Given this list of marker genes AMOT (angiomotin), KANK4, KEL, HDAC6, SEMA5A, BORCS8, MKKS, ESAM, ACTN2, ADD3, SLC12A9, SSH3, CRABP2, SEMA3G, RASA1, WNT3, TMOD2, CCL24, SNAPIN, RB1CC1, SLC12A4, DEPTOR, RAB3B, NAA80, SPTA1, DMTN, C15orf62, MIR214, ADNP, RND2, SPTBN1, ISLR2, CFL2, FCHSD1, HP1BP3, HCK, VIL1, DAAM2, ANO6, NCKAP1L, CORO1A, MEGF8, TMSB4X, WDTC1, STK39 (NCBI Gene Id 27347), CLCN6, NRP1 (NCBI Gene Id 8829), FCHSD2, ABITRAM (actin binding transcription modulator), ARHGAP40, LMOD3, SRF, CLNS1A, SPTBN2, COTL1, BORCS5, USH1C, DISC1, CXCL12, EDN1, CDKL3, CAPZB, ATP13A2, SWAP70 (NCBI Gene Id 23075), NPHS1 (NCBI Gene Id 8183), CHMP3, ZFYVE27, VAV2, SHTN1, PAK3, PYCARD, GSK3B, ALOX15, UCN, NKX6-1 (NCBI Gene Id 4825), CREB1, TRPV4, RDX, OXSR1, BCL11A, POU4F2, ALS2, RNF6, ARFGEF1, TMSB4Y, DSCAM, TRIM46, CSF3, MLST8, CDKL5, RICTOR, IQGAP3, GNB3, RIN3, LMOD1, PRR16, ARHGAP4, MTPN, AKT1S1, CDC42EP5, MAP3K7, WASHC5, MAP3K13, SSH1, SH3BP1, TTL, VASP (NCBI Gene Id 7408), PLXNA3, BRK1, PLEK, PLEKHH2, EZR, RET, SPECC1L, DNAJC16, TP73 (tumor protein p73), NCK1, RHOA, SPTB, RTN4R, RYK, AP2M1, GOLGA4, PICALM, LIMK1, AQP1, SEMA6D, PREX1, SEMA7A, CCL21, SEMA3F, CDHR5, ELAVL1, SLC12A1, ADCY10, IFRD1, PLS1, SEMA6C, ULK1, LRRC8E, NGF, ARHGAP18, KANK1, ARPC5L, ADD1, MSN, IL7R, SCTR, KIAA0319, LRRC8A, TNR, ADD2, BBS4, ARPC5, DRAXIN, DIP2B, FGF13, MYO3B, CRACD, BMPR2, BORCS6, KXD1, DCC, SLC12A7, PTEN, SLC12A5, BAIAP2L2, MAP2, KANK2, CDC42EP4, FSTL4, ARF6, KCNK6, CCL11, VILL, OLFM1, SPTBN4, P2RX7, E2F4, TSC1 (NCBI Gene Id 7248), CARMIL2, CFL1, CDHR2, SEMA4D, LPAR3, CDC42EP1, VAV3, MACF1, RAC1, SEMA3A, CYFIP2, AKT3, SPART, PEX11B, TMOD3, CAPZA3, BIN1, SLC12A6, WNT7A, CDH4, ARHGAP28, WNT3A, PIK3R2, HCLS1, SPP1, KIRREL1, PRKD1, LATS1, ARPC3, CAPZA1, MYO3A, PLXNA4, WAS, FSHR, WNK1, TNFRSF12A, AQP11, HSP90AA1, NEFL, CARMIL1, PTPRS, NRCAM, HIP1R, LAMTOR4, SLC12A2, COL6A1, CCL26, CLN3 (CLN3 lysosomal/endosomal transmembrane protein, battenin), GDI1, SPTAN1, RAB22A, TRPC5, GRB2, PEX11A, ARHGAP35, RAP1GAP2, SLIT1, PRKCE, KCNN4, IST1, ELN, CCR7, AQP4, EVL, PTK2B, SEMA4F, NHERF1, KCNMA1, LMOD2, EPS8, FN1, ABL1, EPHA7, WDR1, RARG, RUFY3 (RUN and FYVE domain containing 3), CAV3, CNTN2, RAB5A, DSTN, CCDC51, EFNA5 (NCBI Gene Id 1946), CYRIB, MT3, DNM1, PEX11G, WNT5A, MTOR, LAMTOR5, KANK3, AVIL, PFN3, TMOD1, BLOC1S2, CDK5, LARS1, F2RL1, BARHL2, PIK3CA, PAFAH1B1, TMOD4, ARPC2, NEB, NPM1, TENM1, BAIAP2L1, SVIL, ASB2, CLASP2, PRKCD, NTN1, BLOC1S1, NTRK3, MAPT, SMURF1, RPTOR, TWF2, GSN, L1CAM, SCT, MAG, LIMA1, SSH2, BORCS7, SPTBN5, CAPG, SLC26A5, TWF1, SNX9, DNM2, CYRIA, PDXP, PLEKHG2, DLG1, WASHC2C, CYFIP1, HAX1, WNK3 (WNK lysine deficient protein kinase 3), TRPV2, ARHGAP5, CDC42EP3 (CDC42 effector protein 3), XK, SLC12A8, BAIAP2, FER, APOE, ULK2, SLC12A3, CTTN, RTN4, CLN8, MAP1B, CLCN3, NCK2, SLIT2, SCIN, TRIOBP, BDNF, PFN1, BAG4, VEGFA, ABCB8, PAK1, GBA2, FLII, GPRC5B, CDC42EP2, ANAPC2, RAB21, NCKAP1, RGMA, MYADM, SHANK3, SIN3A, KDM1A, WNT7B, CAPZA2, PUM2, VAV1, CDH1, PFN2, here is a description of the gene set: Human Gene Set: GOBP_REGULATION_OF_CELLULAR_COMPONENT_SIZE A process that modulates the size of a cellular component. studied in species Homo sapiens